The following is a description of a gene set: Abnormality of connective tissue studied in species Homo sapiens Any abnormality of the soft tissues, including both connective tissue (tendons, ligaments, fascia, fibrous tissues, and fat). Human Gene Set: HP_ABNORMALITY_OF_CONNECTIVE_TISSUE, and this is the list of marker genes: CASK, CHRNG, ZSWIM6, AUTS2, FKRP, LIMK1, SIK1, BRAT1, MID1, CAPRIN1, HNRNPA1, APC, BLM, GNS, FKBP10 (FKBP prolyl isomerase 10), MTX2, GCK, IYD, PIGP, FBN2, SELENON (selenoprotein N), GNB2 (NCBI Gene Id 96628), BANF1, HIRA, TBX15, COG6, DVL1, ALG14, PLCG2, ACER3, STX16, PRKAR1A, ITGA6, ENAM, LMX1B, ADRA2A, FAM20C, KMT2A, RHOA, DUOXA2, PLAG1, SEMA3E, RFWD3, SH2B1, SVIL, DHODH, ALX1, LARGE1, ALMS1, DDR2, PTPN6, COG1 (NCBI Gene Id 9382), WASHC5, ASCC1, STIM1, SALL4, PDPN, TRAPPC14, DDOST (NCBI Gene Id 1650), G6PC3, CAMSAP1, TMEM165, GMPPB, MYL11, DGCR8, JMJD1C, SEC24D, WIPI2, RNASEH2B, AIMP2, GPHN, ASAH1, LMBRD2, CASP10, ADAMTS3, CLCNKB, GJC2, TNPO3, EFNB1, IPO8, BUB1, SKI, DYM, IFNG, ESS2 (NCBI Gene Id 8220), ANKRD1, TFE3 (NCBI Gene Id 8244), CLCN3, SF3B4, CLDN19, BTK, ANKRD55, GTF2E2, HBA1, SDHC, P4HTM, COL1A1, SGCG, TUBA1A, RNF2, ENPP1 (ectonucleotide pyrophosphatase/phosphodiesterase 1), CPOX, KDM5B, GTF2H5, COX11, EXOSC5, TBX4, NHLH2, GATAD1, H19 (NCBI Gene Id 14955), NFIA, CAMLG, ACADM, UFC1, MYO18B, DNA2, FH, RFX5, PCYT1A, PLAA, USF3, SETBP1, AMH, PEX1, KDF1, GLRA1, COL6A2, DCX, GLB1, SPTAN1, SNX14, AMTN, DPYSL5, ANAPC1, PHACTR1, KIAA0753, CD96, GLUL, ARID1A, CDK13, DNAJC21, NUP133, COL5A2, FOXF1, POMT1, DISP1, FOXH1, SMARCE1, IGHMBP2 (immunoglobulin mu DNA binding protein 2, NCBI Gene Id 50985), UBAP2L, MC4R, KMT2C, KIF7, PIGW, NUP88 (nucleoporin 88), HEPACAM, TAPT1, MAPRE2, NOTCH3, ADA2, ORC1, NCF1, COL7A1, GET3, COMT, HK1, SLC9A6 (solute carrier family 9 member A6), POMC, SYT2, ALG2, AP4S1, ECEL1, IL6ST, COL2A1, SMARCD1, RAB3GAP1, CDKN1C, MSH2, KLHL9, ZFPM2, SLC12A3, DLL1, DYSF, ECM1, VDR, SNUPN, SLC37A4, IBA57, ALS2, PRKG1, ATP2A1, PNPT1, HBA2, PTF1A, AGRN, LUZP1, SMARCA2, RARS2, ANGPT2, DMP1, TBC1D20, SLC35C1 (NCBI Gene Id 55343), GJA5, BCOR, SMC3, CDKN2B, HYMAI, HYAL1, HS6ST1, LAMA4, CC2D2A, THSD4, DARS2, ARFGEF2, GPC4, MYPN, SPI1, NECTIN1, HLA-DRB1, SMARCA4, GNE, TGFBR1, DNMT3B, MAP3K7, SPART, HLA-DQA1, IMPDH2, HSPD1, DNAJB6, FARSB, GLE1, FOXE3, ESCO2 (establishment of sister chromatid cohesion N-acetyltransferase 2), OCRL, CHD3, NSD1, IFT52 (NCBI Gene Id 51098), AGA, ALG3 (ALG3 alpha-1,3- mannosyltransferase), PDE11A, HLA-B, TCAP (NCBI Gene Id 8557), DPM1, LPIN2, SALL1, GNRH1, CHRNB1, MMP1, DLL3, VEGFC, MSH6, KCNJ8, NSDHL, EMD, WDR26, MUSK, C1R (complement C1r), DPH1, TGFBR2, WRN, MEG3, SLC2A10, CHRNE, CCBE1, RAC1, SLC12A1, XRCC2, KISS1, RPS28 (ribosomal protein S28), SPARC, SCYL2, WDR72, HEXB, GFPT1, PORCN, CLIC2, TRPV6, TNFRSF11A, CYP26C1, RBM20, HSPB1, SNAP25, LRP6, MSX1, REV3L, IRF5, KMT2B, LTBP1, SLC1A2, GJB1, NKX2-5, WDR4, PBX1, MT-TQ, CNNM4, PI4KA, BMPER, DDX59, SMOC2, KCNQ1OT1, NODAL, FUS, SLC32A1, TMEM270, COL25A1, MAD2L2, GPR68, LMNA, DHCR24, NPHP3, DOK7, ADNP, JARID2, RNF113A, LOX, NT5C2, CSRP3, NGLY1, FANCM, PLCH1, CBS, GRID2, USP7, SLC39A14, PDHA1, SDHAF1, PLD1, DVL3, OTULIN, OCLN, AP4E1, ADCY6, GFM2, KLHL7, FANCF, TAF6, CDH3, FANCL, MT-TP, GFI1, DYRK1A, UROD, CTBP1, CDC6, NCSTN, FUCA1 (NCBI Gene Id 2517), TMEM218, PSMB4, DMD, TYROBP, COX7B, CADM3, MT-TE, VPS35L, SPRY4, PIGQ, UNC80, NSD2, EDARADD, TBCK, TCIRG1, FBXO11, ORAI1, TMEM43, FLVCR1 (FLVCR choline and heme transporter 1), NMNAT1, PIK3C2A, MFN2, IDH1, P3H1, LMF1, SOX18, SYT1, KMT2D, TMEM216, NUP107, PMM2, VPS37D, PRKCZ, PIK3R1, LONP1, B3GALT6, ESPN (NCBI Gene Id 83715), EXT2, GALNS, TGFA, NKX6-2, NSRP1 (NCBI Gene Id 84081), PEX7, SLC35A2, TNNT2, CRPPA, OTUD6B, ELANE, MMP20, MAPK1, POLA1, SLC4A10, CWC27, LAMA5, POU1F1, TBXT, NUP85, FGD1, USP48, DLX4, BUD23, CENPE, ARMC5, FKBP6, SATB1, BMPR1A, AXIN2, EXOSC3, ABHD12, VRK1, KIAA0586, SMC1A (NCBI Gene Id 8243), L1CAM, LMOD3, C19orf12, PDGFRB, TG, TRRAP, SIN3A, RECQL4, POLR3A, UCHL1, COQ7 (coenzyme Q7, hydroxylase), SHPK, STRA6, FANCB, PPP1R21, MAFB, GLIS3, PPP2R5D, KIF1A, PSEN1, AEBP1, ABL1, ANKLE2, FGFR3, SLX4 (SLX4 structure-specific endonuclease subunit), NTRK1 (NCBI Gene Id 7825), HES7, CDK5, BRAF, ITGB4, FREM1, MEIS2, PACS1, CDKL5, PRUNE1 (NCBI Gene Id 91961), LMBR1, DYNC2I1, H4C9, HIC1, TMEM38B, BRIP1, SEC24C, CTSK, ERLIN2, GLRB, RAD21, SUZ12, ZNHIT3, PHF6, CRIPTO, POR, IFT81, CAPN3, SDHB, NR4A2, IL17RC, PIGN, TP53, LAGE3, SLC29A3 (solute carrier family 29 member 3), BMP4, LIPE, CEP120, ZIC3, POLR1D, NF2, DSG2, GON7, CFI, SIX3, ATAD1 (ATPase family AAA domain containing 1), BTNL2, CLCN4, PHGDH, HOXC13, KCNJ11, NEK9, TXNL4A, ITGA7, DYNC2H1, NAT8L, VPS33B, PSMB8, SRPX2, TGDS, TRPV4, IL17F, POLD3, TBCD, HEY2, SERPINF1, ZC4H2, XRCC4, RBM28, GRIA4, PRDM10, TBL2, TPM1, CIB2, RPS26, VANGL1, SHH, COL12A1, AR, ALG9, COLEC11, CLMP, FLVCR2, THRA, HMGA2, GTF2IRD2, BMP1, BRPF1, SH3BP2, IFT80, MYH2, SNRPB, FGF8, PPP1R12A, DSP, PAX9, CFL2, ALG1, HINT1, PLOD2, PPM1D, TNNT3, AGTPBP1, TSC1, GJB6, PNKP, SLC39A8, TOR1AIP1, FOXP1, NLRP1, WT1, GP1BB, SLC35A3, RPS20, LAMB3, AKT2, SET, UHRF1, JPH2, COL6A1, FLNA, SERPINA1, DPM2, TPO, LFNG, KIF5C, DST, POGZ, CCDC22 (coiled-coil domain containing 22), F8, ZBTB42, DICER1, KCNH1, LHX3, KISS1R, NEXN, FITM2, ERMARD, DUSP6, AMBN, FOXE1, ERBB3, LIFR, USH1C, GORAB, ARVCF, PIP5K1C, NFIX, KY, MT-TH, TP63, IKBKG, TRIP13, LETM1, COG3, SLC16A2, TNNT1, RNASEH2A, PEX6, NR2F2, DEGS1, PLXND1, ELN, GUSB, EXOC2, EHMT1, HLA-A, NACC1, KAT6B, GABRD, THOC6, ADGRG1, GNA11, PUF60, SP7, AIRE, PIK3CD, ZMPSTE24, HOXD13, ABCD1, FAM20A, FILIP1, BRCA1, TPRKB, PCSK1, PIGY, MEN1, POMT2, PTPN22, STAC3, TBC1D2B (NCBI Gene Id 91449), FBLN5, LRPPRC, RAP1B, FGF3, DIS3L2, CNTN1, PPCS, PSMG2, YY1, ARPC1B, WNT4, HPDL, PAX7 (NCBI Gene Id 5081), NDUFAF5 (NCBI Gene Id 79133), TNXB, ADAR, ARID2, NOG, KDM5C, INPP5K, GCH1, HPGD (15-hydroxyprostaglandin dehydrogenase), SHANK3, MYH11, CLDN1 (NCBI Gene Id 9076), WNT3, CHST3, PSEN2, CCDC32, TAFAZZIN, NR3C1, COL11A1, PRKACA, MSTO1, PAX8, NDE1, SLC5A5, CCR6, TRAK1, PRR12, FTO, CD79B (CD79b molecule), DYNC2I2, CSGALNACT1, HCCS, ZEB1, NEFL, HELLS, TASP1, WNK3, KBTBD13, CAMTA1, SMPD4, BCL11B, ALPL, TRIP11, PAX3, POMK, PYCR1, PDX1 (NCBI Gene Id 3651), TSEN54, KCNK9, MECP2, TMCO1, TENT5A, DNAJB4, CXCR4, KCNJ6, MPLKIP, FHL2, CDON, ATRX, STAT4, GPC3, COLEC10, TCTN3, PSAT1, BCR, ARF1, EN1, IL2RA, VMA21, RAF1, MBTPS2, RNU4ATAC, TLK2, NSMF, UBE4B, SEC23B, SRCAP, ATP6V1A, ACTC1, UFD1, NSUN2, SLC10A7, CDC42, SMAD4, INSR, KLLN, H3-3A, DEPDC5, WNT7B, CDH11, ATM, BLTP1, ELOVL4, WDR45B, ATP11A, STAT3, TREX1, CTCF, ZBTB24, ROR2, MYOD1, PEX2, ATP1A2, FLRT1, DOCK11, TTN, ZFHX2, BCAS3, SLURP1, MYH8, KDM1A, KIF5A, FAM111B, LZTR1, EZH2, LIAS, ADAT3, TWIST2, PRDM5, SEPSECS, FLI1, INPP5E, KDM3B, EPCAM, ZNF407, IRX5, GTF2IRD1, SAMHD1, TACR3, FANCI, SLC5A6, MT-TS2, TUBB, POLR1C, CHMP1A, IRF6, GBE1, ATP5F1D, INF2, POLR2A, TMEM94, KCNAB2, IL6R, OPA1, CRELD1, MRPS34, RIC1, HAND2, SATB2, UBA1, TGFB2, PTH1R, NCF2 (neutrophil cytosolic factor 2), SGSH, DCHS1, MBTPS1, GRIP1, GARS1, MFAP5, SH3PXD2B, TRPS1, MIA3, SON, PPIB, CTSC, RFX7, MYBPC1, RFC2, WNT10B, LGI4, HESX1, CCN2 (cellular communication network factor 2), WDR73, TNNI2, SIGMAR1, MORC2, COG5, CARS1, SLC25A19, GRHL2, OBSL1, LMOD1, CCN6, TRIM37, COL3A1, FLNB, POLD1, PAFAH1B1, RFC1, HDAC8, PMP22, IFT43, NECTIN4, LRP2, NXN, TOP3A, NOTCH2 (notch receptor 2), VIPAS39, SLC5A7, ATP6V1E1, CDC73, CDH23, CTDP1, CYBA, SPECC1L, GLI3, NEB, DDX6, DUOX2, RAD51C, DNM2, PRDM12, FZD2, ANO5, NKAP, CACNA1E, GLDN, TNRC6B, CYBB (NCBI Gene Id 1536), PIGL, FLT4, PAK2, FAM83H, ATRIP, ERCC6, MAGEL2, DNAJC30, SERPINH1, MEGF10, PALB2, AHDC1, THBS2, LMNB2, CLEC7A, ERI1, STX5, MMP23B, MTMR14, COL5A1, CDC42BPB, MET, LCK, GALNT3, HDAC4, ACADS (acyl-CoA dehydrogenase short chain), PROKR2, PRIM1, FRAS1, MTRFR, ZFX, SMCHD1, CHD7, TGFBI, TMEM107, MARS1, ALG11, METTL27, KLK4, SHOC2 (SHOC2 leucine rich repeat scaffold protein), NDUFA8, CACNA1A, MNX1, CHEK2, MMP14, DHX16, DPP9, INS, WDR19, EMG1, CIDEC, TRIM2, NOD2, CRLF1, ISL1, TRMT10A, NELFA, PIGG, SDHD (NCBI Gene Id 91899), SLC24A4, CDKN1B (cyclin dependent kinase inhibitor 1B), VAMP1, AKT1, JUP, EIF5A, MASP1, DIAPH1 (NCBI Gene Id 1729), ACTG2, AIMP1, BRF1, HLA-DQB1, PCNT, CHAMP1, SCN4A, PPP1R15B, TNFRSF11B, NEUROD2, ADSS1, CPLX1, LAMA3, MED12, PLEC, SMAD3, SEC31A, ZPR1, GNAS, PYROXD1, EDA (NCBI Gene Id 90878), H4C3, CUL4B, BRD4, ZFP57, PLN, SMG9, SLC26A4, TSHB, FAS, P4HB, UBE2T, MTHFR, DPAGT1, PLOD3, RYR1, PPP3CA, SIL1, RBBP8, KIF14, BAZ1B, ZNF335, DNMT3A, PPOX, IDUA, ANTXR1, FGF17, ACTN2, MT-RNR1, CLPB, CCDC8, CLCF1, CHRND, VCL, ALDH1A2, TAF4, ZNF469 (NCBI Gene Id 84627), TREM2, RNASEH2C (NCBI Gene Id 84153), ERCC3, GPC6, MTFMT, SPTLC1, BGN, SLC2A2, PROP1 (NCBI Gene Id 5626), PPT1, CLDN16, NALCN, SLC39A7, GPKOW, ACP4, KIDINS220, MYMK, POLR3GL, GAS1, DMXL2, MLH1, CHN1, LTBP4, WHRN, RAB3GAP2, CARMIL2, EXOSC9, RPGRIP1L, KIAA0319L, DSPP, H4C5, BRCA2, SUCLG1, CSNK2A1, VWA1, LAMC2, PLIN1, MYRF, SLC26A2, ERCC1, ALDH3A2, ITGB6, MAD1L1, OFD1 (OFD1 centriole and centriolar satellite protein), EXOSC8, NOTCH1, MYL1, SLC12A6, SLC35A1, SNIP1, FIG4, GRIN1, TMEM67, PPP2CA, TCF4, LDB3, PDXK, SOX6, SKIC2, PDZD7, SKIC3, DLK1, ASXL1 (NCBI Gene Id 23393), AGGF1, IGF2, CCL2, PIK3CA, PTRH2, ORC6, SYNE1, TPM3, GBA1, GTF2I, TBX2, KCTD1, ERCC4, WNT5A, TTC7A (tetratricopeptide repeat domain 7A), PLA2G6, MECR, FKTN, AHSG, SLC25A24, PLEKHG5, B3GLCT, TAC3, PLCB4, KCNJ2, MEGF8, ADGRG6, MAF, ZBTB20, MAN2B1, PPP2R1A, ANAPC7, TARS1, TNFRSF1A, PQBP1, SLC25A46, ALG13, KRAS, PKP1, B9D2, RAC2, CHRNA1, SLC25A22, MAN1B1, TFAP2A, TNNI3, ARID1B, IFT122, MT-TF, RTTN, CREBBP, LMOD2, POMP, HGSNAT, PERP (NCBI Gene Id 64065), FLCN, ARPC4, ODAPH, PTCH1, DACT1, VARS1, DGCR2, MYH6, SRD5A3, MUTYH, SLC18A3, TRIM8, UPF3B, PLS3, ORC4, PTPN2, RIPK4, RYR3, NKX2-1, GNPNAT1, TCOF1, FXYD2, VANGL2, KLC2, PEX5, FUT8, AIFM1, CNTNAP1, MT-ND5, MAMLD1, TRPV3, CHCHD10, GNPTG, POP1, IGF1R, ALX3 (ALX homeobox 3), GRM7, PGAP1, IFT56, TMTC3, MAP3K20, RNU4-2, MEFV, SMAD2, ASXL3, RIN2, MED13L, TBCE, NDUFB11, PTEN, NDUFAF4, ACTA2, NAA10, DOLK, PIGS, MLXIPL, NKX3-2, POLR1A, SPRTN, ZDHHC9, VPS11, DPH2, EOGT, SPTSSA, LEMD3, LRRC8A, IARS2, TRAIP (NCBI Gene Id 10293), REEP1, RNU7-1, RAPSN, ALB, TOR1A, MT-TL1, SLC13A5, NLRP3, BLNK, OTUD5, SEMA4A, ATP6V0A2, ERLIN1, NUP188, CANT1 (NCBI Gene Id 619513), MKS1, CPT2, TSC2, CEP152, SCARF2, XYLT1, CD79A, DLG5, PYCR2, MED11, FIBP, CAV1, RUNX2, ACTB, IL17RA, USP8, SGCA, LHX4, GATA6, LDHD, CEP55, MPDU1, IFITM5, POLR1B, COL11A2 (NCBI Gene Id 494120), KIF26A, HACD1 (3-hydroxyacyl-CoA dehydratase 1), ZBTB7A, FANCA, WDR35, MAP1B, C18orf32, SPTBN4 (NCBI Gene Id 80322), COL6A3, SP6, COG8, FAT4, CRKL, CAVIN1, NDRG1, FANCD2, LRP1, GNAO1, AMELX, CD247, RAB23 (RAB23, member RAS oncogene family), ERGIC1, SMOC1 (SPARC related modular calcium binding 1), NCAPG2, ADGRV1, GDF11, TRIP4, KDM6A, BAG3, PPARG, MED25, KRT9, ODC1, CAP2, HAVCR2, ABCC6, COL13A1, DDC (NCBI Gene Id 9492), TGM1, EP300, MPEG1, CYP2R1, MYBPC3, TXNRD2, RNF13, ADAMTSL2, FANCC, ATP7B, WNT10A, SLC25A1, CLDN11, TPM2, ECE1, IDS, MMP2, PROK2, MYH7, GAD1, RERE, CDC45, FUZ, KRT14, PLOD1, SYNE2, GOLGA2, LMNB1, CLIP2, ATPAF2, DAG1, VPS33A, GDF5, LRP4, SOX4, PLAGL1, SPG11, STIL, IGHM, KIF11, KLHL41, COQ6, ERCC5, PCDH15, GATA1, PDE4D, TRAF7 (NCBI Gene Id 84231), UROS, GRIN2B, BAG5, MPV17, EIF4H, ABCC8, ROGDI, KIF21A, IFIH1, SLC6A5, SRP19, TNNC2, AGPAT2, EFEMP1, HRAS, RLIM, HNRNPA2B1 (heterogeneous nuclear ribonucleoprotein A2/B1), MYH3, CDCA7, JAG2, SGCD, KRT5, EXOC8, TELO2, RAB18, COQ4, FREM2, WLS (Wnt ligand secretion mediator), PLK4, AMHR2 (NCBI Gene Id 269), GATA2, ITCH, LTBP3, GLI2, NRCAM, SLC39A13, BSCL2, SPEG, TNNC1, BIN1, GZF1, SCN1B, KCNA1, RPL3L, DDHD2, ALDH18A1, RTL1, RARB, PLP1, PSTPIP1, ABCC9, TMEM70, MYSM1, CUL7, GCM2, GNPAT, RREB1, MESP2, FBXO28, FOSL2, EFEMP2, FDFT1, CACNA1C, USH1G, HYLS1, ZEB2, TDO2, AP2S1, FERMT1, EPHB4, MYO9A, RSPO2, RIPPLY2, MYLK, GJA8, DGCR6, FLNC, RPS6KA3, SOX10, USH2A, CCDC134 (NCBI Gene Id 79879), LIMS2, GPT2, AP4B1, ERCC2, ALG8, SLC1A4, EPB41L1, DNASE2, WNT7A, NFATC2, SMARCC2, MTOR, RAD51, STX1A, B4GALT7, COL1A2, FBXW11, PHEX, KIF15, TRAF3IP2, CRTAP, PCNA, GDF1, KLHL40, GDAP1, RFT1, MCTP2, EXTL3, FASLG, PRG4 (NCBI Gene Id 787), FANCE, SIK3, EED, FGFR1, TMPO, VPS53, GMNN, VPS4A, CHST14, SPRED1, FANCG, TGFB3, CTNND2, ARSB, POLE, LAMA2, SLC35D1, SMS, SEMA5A, KRT16, GSC, TAF1, SMARCB1, FOS, CYP27B1, KCNQ1, COL17A1, SOX11, NPPA, HIVEP2, ALG12, GATA4, MAT2A, YRDC, STAG2, ADAMTS2, MSL3, FOXC2, PMS1, TBR1, ATP7A, TCF3, GNRHR, ZIC2, SCN5A, NARS1, VEZF1, PIK3R2, PTDSS1, TMEM222, PLAAT3, DRG1, DHCR7, PIGA, HS2ST1, GNPTAB, LEMD2, ARX, AMER1, IGLL1, HIKESHI, RELT, B3GAT3, YWHAE, SCUBE3, MYT1L (myelin transcription factor 1 like), RMRP, BHLHA9, TBL1XR1, FOCAD, ALAD, MDFIC, KRT1, SOX9, MN1, FGF10, ERCC8, HUWE1, KCNJ1, SMARCD2, SDHA, FHL1, PIEZO1, BICD2, FBXL4, IL2RB, NEDD4L, COASY, GJA1, ADAMTS15 (ADAM metallopeptidase with thrombospondin type 1 motif 15), TBX3, MYO7A, MT-TK, FKBP14, TBX1, TAF1A, SUMO1, LSS, GJB2, FCSK, CRYAB, EBP, KCNN3 (potassium calcium-activated channel subfamily N member 3), H1-4, IFT140, TP53RK, ATR, FGFR2, PRKG2, CHAT, NIPBL, CHUK, PIEZO2 (piezo type mechanosensitive ion channel component 2), KNSTRN, LBR, DES, TGFB1, SPEN, APC2, NF1, KIF22 (kinesin family member 22), TUBB3, ABCD4, AARS1, LSM11, HSPG2, SLC6A9, SIX6, ACTA1, SCN2A (NCBI Gene Id 94312), DLX3, ANTXR2, C1S, NUAK2, TGIF1, RNU12, DPF2, RPL10, FBN1, CDKN2C, WDR11, ANKH, MTM1, SMARCAD1, OSGEP, MYL2, DSE, CASZ1, ZNF699, CDKN1A, CDT1, EXOC7, AP1S2, TSHR, MYOT, CCDC47, ELMO2, PPP2R3C, NEU1, PRDM16, SLC25A4, PMS2